Given this list of marker genes Sox9, Dmrt1, Nr0b1, Igf1r, Foxl2, Map3k4, Slx, Wnt4, Slxl1, Insr, Ptgdr, Tcf21, Amh, Nr5a1, Sf1, Six4, Sry, Tmem184a, Dhh, Wt1, Insrr, Rsl1, Sox3, Sly, Ar, Cited2, Fgf9, Gnrh1, here is a description of the gene set: Mouse Gene Set: GOBP_SEX_DETERMINATION Any process that establishes and transmits the specification of sexual status of an individual organism. species: Mus musculus